Given this list of marker genes SOAT1, RREB1, ATP11AUN, HOXA3, HOXC4, TAF15, CCND1, PRMT5, DCDC1, HOXB8, ME3, MEIS1, TEX26, CIB3, CSF2, KCNT2, CACNA2D3, GABRA6, SLC17A6, PTMA, TP63, CALCR, PHC2, EBF2, TAC1 (NCBI Gene Id 6864), ATP6V1B2, ENSG00000291228, THPO, NFIX, RALYL, RSF1, EGR1, FAM169BP, HERC4, SCRT2, CASKIN1, ADAMTS6, FOXF2, STMN2, MDFIC, CHD2, ADAM11, MYO1B, TMSB4XP6, SIAH3 (NCBI Gene Id 283514), SULF2, HOXA9, AAMDC, HS3ST3A1, POU2F1, PPP2R5D (protein phosphatase 2 regulatory subunit B'delta), GC, BAZ1A, NDUFA4L2, CDK19 (NCBI Gene Id 23097), HOXC6, RERE, ACER3, FGF13, NEUROD6, ST6GALNAC5, WDPCP, DPH3, ALB, OXNAD1, FYN, IRX4, CNTLN, PIPOX, CELF2, NKX2-2, HTR4, CAST (NCBI Gene Id 831), CEACAM19, OTP, AFP, FGF12, FOXA2, TMSB4XP8 (NCBI Gene Id 7117), SMOC1, TTR, ZBTB18, STMN4, ESRRG, EDEM1, TMSB4XP1, UBR5, MITF, PRDM12, MN1, KLF14, MGAT4C, SLC5A12, SVIL (NCBI Gene Id 6840), TMSB4XP4, here is a description of the gene set: Genes having at least one occurrence of the motif CCAATAATCGAT in the regions spanning 4 kb centered on their transcription starting sites. This matches the CUTL1 transcription factor binding site V$CDP_01 (v7.4 TRANSFAC). Human Gene Set: CDP_01 studied in species Homo sapiens